Given this list of marker genes Vsig4, Btnl2, Vtcn1, Irf4, Rps3, Stat5a, Homer3, Ezr, Pnp2, Pde4d, Pawr, Clec2i, Anxa1, Hdac7, Prkd2, Nav3, Il1rap, Nr1h4, Cd247, Laptm5, Glmn, Tnfsf4, Card9, Cd1d2 (CD1d2 antigen), Gpam, Sftpd, Nod2, Plcg2, Sash3, Slc11a1, Gpr174, Gata3, Oscar, Kat5, Il1a, Abl1, Carmil2, Stoml2, Cd276, Trim27, Sptbn1, Cd1d1, Cd28, Abl2, Tbx21, Cd34 (NCBI Gene Id 98592), Prkcq, Lilrb4a, Cd83, Lilrb4b, Pnp, Malt1, Lag3, Xcl1, Il1b, Runx1, Card11, Prnp, Tnfaip3, Il17f, Defb25, Ccr2, Zfp36, Ptprc, Ripk2, Homer2, Foxp3, Cd3e, Il20rb, Stat5b, Fcer1g, Fosl2, Clec7a (NCBI Gene Id 56644), Pde4b, Traf2, Traf6, Map3k7, Havcr2, here is a description of the gene set: studied in species Mus musculus Mouse Gene Set: GOBP_INTERLEUKIN_2_PRODUCTION The appearance of interleukin-2 due to biosynthesis or secretion following a cellular stimulus, resulting in an increase in its intracellular or extracellular levels.